The following is a description of a gene set: A process that is carried out at the cellular level which results in the assembly, arrangement of constituent parts, or disassembly of the nuclear envelope. Human Gene Set: GOBP_NUCLEAR_ENVELOPE_ORGANIZATION studied in species Homo sapiens, and this is the list of marker genes: NEMP1, PRKCB, CHMP3, CHMP5, VPS4B, CDK1, DMPK, NUP93, NEK6, REEP3, TOR1B, PARP11, CHMP2B, CHMP7, LMNB2, TOR1AIP1, CHMP1B, TOR1A (NCBI Gene Id 1861), NUP155, NSFL1C, CHMP4A, UBXN2A, CHMP4C, TMEM170A, RCC1, PAFAH1B1, EMD, ATR, LMNB1 (NCBI Gene Id 445266), CHMP1A, TMEM43, PRKCA, BROX, UBE2I, CHMP2A, CHMP6, TARDBP, BANF1, LMNA, LPIN1, DCTN1, GPER1, ZMPSTE24, TMEM201, DES, AKAP8L, ANKLE2, VPS4A, CHMP4BP1, CTDNEP1, UBXN2B, REEP4, LEMD2, CHMP4B, SPAST, PLK1, SIRT2, VRK1